Given this list of marker genes CALM2, LAMP2, VEZF1, CALM1, KCNJ18, CDC45, GABRA3, BVES, LARS2, NPPA, CACNA1S, SCN5A, CALM3, LMNA, CACNA1D, here is a description of the gene set: studied in species Homo sapiens Second degree atrioventricular block An intermittent atrioventricular block with failure of some atrial impulses to conduct to the ventricles, i.e., some but not all atrial impulses are conducted through the atrioventricular node and trigger ventricular contraction. Human Gene Set: HP_SECOND_DEGREE_ATRIOVENTRICULAR_BLOCK